The following is a description of a gene set: The movement of a sphingolipid molecule from one leaflet of a membrane bilayer to the opposite leaflet. species: Mus musculus Mouse Gene Set: GOBP_SPHINGOLIPID_TRANSLOCATION, and this is the list of marker genes: Abcc1, Abcb1b, Abcb1a, Abca2, Abca1